The following is a description of a gene set: studied in species Homo sapiens Human Gene Set: ATF4_Q2 Genes having at least one occurrence of the motif CVTGACGYMABG in the regions spanning 4 kb centered on their transcription starting sites. This matches the ATF4 transcription factor binding site V$ATF4_Q2 (v7.4 TRANSFAC)., and this is the list of marker genes: HNRNPAB, TIPRL, NFKBID, SYT2, ADISSP, EIF4G1, RAI1, PAX3, YJU2B, TMEM86A, PNMA3, CDC14B, FGF14, GGN, MYBPH, LPP, XPO1, SLC49A4, PKIA (cAMP-dependent protein kinase inhibitor alpha), TSC22D2, MAP1LC3A, PNMA6A, IRX6, MARCHF6, JPT1, TPM4, SCAMP5, PSME4, KLHL18, MRPS18B, ZFAND5, AHI1, DDX51, PSMD7, AP2M1, PAK1, CHAC1, AHR, SMARCAD1, CAPN6, MPP2, PDE4D, FAM167A, PTGES3, ZBTB20, PHACTR3, PAK3, RBBP8, ANKS1A, ABHD11, CTC1, TBC1D32, SNRNP40, BUD31, PRICKLE1, CNBP, BMF, SIK2, PCDH9, PTPRU, ZHX2, PLEKHH3, MAF, PABPC1, TMEM54, THADA, SIK1, MTF1, HS3ST2, IRF2BPL, RBM18, MYRF, GJD2, NPTX1, MAP3K13, KDM3A, PPP1R10, CDH23, TSC22D3, OGDH, UBE2H, SGK1, RBP5, RAB7A (RAB7A, member RAS oncogene family), FYTTD1, ROM1, PAK6, BRAF, SREBF2, USP2, EPHA2, PPP1R15A, NOC4L, PITX2, MACO1, ZZEF1, NOL4, TNXB, RELB, DDX3X, NR4A2, MSX2, CAPN12, MAOA, PRR7 (proline rich 7, synaptic), CTCF, FOS, ARG2, PENK, SORBS1, ADAP1 (NCBI Gene Id 11033), PNRC1, LAMC2, CBX3, CPT1B, KIF7, KCNJ2, SRSF1, PAH, LINC02908, PEX12, LTBP1, CLC, PNPLA3, GRM3, AMMECR1L, HP1BP3, FOXD3, NDRG2, S1PR2, ID1, KCNN2, TDG, COQ8B, ALKBH5, PLSCR3, ZNF516-DT, LRRN4CL, SIDT2 (NCBI Gene Id 51092), PSMD12, HHEX, ITPKC (NCBI Gene Id 80271), ZNF423, DCTN1, NR2E1, SDHB, SMARCB1, XIRP1, ZNF711, PDP1, DHX36, RIPOR1, DUSP1, RFX5, BAZ2A, TEX14, ITM2B, KLF13, C11orf87, UBQLN2, DERL1, GNAS, PPP2R5B, SMAD1, MRRF, TRIM39, NUP98, NF1, NR4A3, GABRA1, GTF2A1, RPS6KA4, LEPROTL1, KIF9, JAG1, SV2B, BAHD1, CMSS1, HNRNPA2B1, TMEM39A, VPS37B, NRIP3, ZNF687, MRGPRF, NDUFA10 (NADH:ubiquinone oxidoreductase subunit A10), HOXC10, TRIB1, ICA1, BICDL1, TLNRD1, FAM131A, SLC18A2, MIR9-1HG, FOSB, CHD2, IKBKB, CDC5L, LMTK2, CENPE, NUP42, RNF44, STIM1, ALDOA, ADGRG1, POLR3E, LMO4, CLSTN3, SLC38A2, ELOVL5, SELENOM (selenoprotein M), GEM, SYNGR3, PHF8, ABCD1, PAFAH1B1, CIRBP, PDAP1, CXCL16, SLC35F5, NKX2-1, MBNL2, USP14, SKIDA1 (NCBI Gene Id 730417), TUG1, ZFYVE27, BSN, ATF1, ST8SIA5, F2RL2, XPOT, DAAM2, KRT36, PSMD4, PSD, PRR3, RAB25, EML3, SULT4A1, USP48 (ubiquitin specific peptidase 48), NRXN2, GPM6B, JOSD1, CDK5R1 (cyclin dependent kinase 5 regulatory subunit 1), SMARCA1, KAT5, FLNC, TAFA1 (TAFA chemokine like family member 1), AKIRIN1, TAB2, PRRC2C, ATG5, ZMYND15, HCST, GSK3B, CYP24A1, ABCA2, GNL1, TAF11, ENO1, ECM1, RASGEF1A